The following is a description of a gene set: studied in species Homo sapiens Human Gene Set: GSE17580_UNINFECTED_VS_S_MANSONI_INF_TREG_UP Although several markers have been associated with the characterization of regulatory T cells (Treg) and their function, no studies have investigated the dynamics of their phenotype during infection. Since the necessity of Treg to control immunopathology has been demonstrated, we used the chronic helminth infection model S. mansoni to address the impact on the Treg gene repertoire. Before gene expression profiling we first chose to study the localization and antigen-specific suppressive nature of classically defined Treg during infection. Presence of Foxp3+ cells were found especially in the periphery of granulomas and isolated CD4+CD25hiFoxp3+ Treg from infected mice blocked IFN-gamma and IL-10 cytokine secretion from infected CD4+CD25- effector T cells (Teff). Furthermore the gene expression patterns of Treg and Teff showed that in total genes were significantly regulated during chronic schistosomiasis. Upon k-means clustering we identified genes exclusively regulated in all four populations including Foxp3, CD103, GITR, OX40 and CTLA-4: classical Treg markers. During infection however, several non-classical genes were up-regulated solely within the Treg population such as Slpi, Gzmb, Mt1, Fabp5, Nfil3, Socs2, Gpr177 and Klrg1. Using RT-PCR we confirmed aspects of the microarray data and in addition showed that the expression profile of Treg from S. mansoni-infected mice is simultaneously unique and comparative with Treg derived from other infections from publication Layland LE, Mages J, Loddenkemper C, Hoerauf A, Wagner H, Lang R, da Costa CU (PMID 20007528) Genes up-regulated in comparison of regulatory T cell (Treg) from uninfected mice versus regulatory T cell (Treg) from mice infected with S. mansoni., and this is the list of marker genes: RPL5, CASP8, MS4A6A, OAS2, BLK, PDLIM1, TDRP, BMF, CTCF, BOLL, RASGRP1, LTA, OTUD5, TRIM24, ASPSCR1, ATP1B3, ING4, DUSP2, METTL17, CCR7, FZR1, GPR83, DFFA, CDK11B, TMEM184C, SP6, PILRA, FASTK, CD19, METTL25B, C1orf131, B3GNT3, DOK3 (docking protein 3), PTPRA, SMAD3, CCDC6, BTG1, APOA5, CYP46A1, EEF1G, GRIN2A, SFSWAP, HNRNPH3, BCL2, STK38, ZC3H7A, BRWD1, NFKBIZ, TBX6, RPGRIP1, TERF2, ATG2B, GFRA1, CD22, KCNK1, CRYZL1, CD37, AKAP9, MALAT1, H2AC25, ICE2, INTS6L, IL12A, BACH2, AAMP, GGT5, DGCR8, CDK12, BMAL1, CLK1 (CDC like kinase 1), RHBDD2, EMSY, FBXL3, IKZF2, SPIB, CA12, KLF7, APPBP2, VPS37C, MDP1, RESF1, ZBTB20, RUFY1, STXBP4, SNX30, IER2, ADAT1, PXMP4, FGF11, ACP5, TNFSF8, RABGAP1L, ZFR, LRRC23, LSP1, PDS5A, IFIT2, AACS, TRIM44, EIF3E, SMC4, SMAGP, SMC6, SCGB1A1, TXNDC16, KIF1B, PI15, ZFYVE19, TP53INP1, LMBR1L (limb development membrane protein 1 like), MADD, PLEKHA1, PPP2CA, RSPH6A, GNB4, PRSS12, SKIL, SLC9B2, DDX41, PURA, SFXN2, GFM2 (GTP dependent ribosome recycling factor mitochondrial 2), COL9A3, HLA-C, DIABLO, RMND1, SNAPC3, HYAL3, MMP17, MAP2K1, PTBP2, UGCG, FAAH, TNNT2, PRKCD, NELFA, PRPF38B, SH2B3, ARFIP2, RNF167, LTB, PECAM1, PIAS4, OASL, RASIP1, RPP14, INTS11, DDC, B3GNT2 (UDP-GlcNAc:betaGal beta-1,3-N-acetylglucosaminyltransferase 2), SLC17A9, TAOK1 (TAO kinase 1), ASH1L (ASH1 like histone lysine methyltransferase), SARDH, ZNF235, UGGT1, RAPGEF4, RASAL3, RAD51D, LMO4, MAPK10, INPP1, ABCB9, NRAS, ALS2CL, BICD2, CR2, ING1, DGKQ, S1PR1, ITM2A, MS4A1, RASA1, PIP5KL1, SELL, PIGN (phosphatidylinositol glycan anchor biosynthesis class N), SH3GLB2, TNFSF14, CCNL2 (NCBI Gene Id 9613), BIN1, FCER2, RBM22, SESN1, RAC2, MAP4K2, SCD (stearoyl-CoA desaturase), DMAC2, PHYHD1, REL, RANBP17, IRF7, TTLL3, GIMAP4, IFT172, PEA15, MSL1, CCDC137, ITGA5, MDN1 (midasin AAA ATPase 1), RUFY2